Given this list of marker genes TGFB3, HSD3B7, POU4F2, OR1E2, COMMD10, CNTFR, IKZF2, NBEA, KMT2A, SOX10, TBX4, TNXB, CREB5 (NCBI Gene Id 9586), HOXC4, FOXB1 (forkhead box B1), ATG2B, SLC6A12, GRHL3, FBXL20, JAML, IGFBP3, TNFRSF1A, GPX1, GNAO1, ELF5, CEP15, ARHGAP5, MARCHF1, SOX21, SNX2, TEAD1, CD84, ZNF644, PTGER1, GHR, LASP1, NOTUM, COL8A1, EGFLAM, MBOAT7, FOXP2, RBMXL2, SREK1, VAMP8, BRINP3, GTF2E1, WDR47, LIMS1, SSBP3, SLITRK1, RBM14, TLL1, IL2, COL16A1, SPINK5, CNOT1, NTM-AS1, TFDP2 (transcription factor Dp-2), MARCKS, NMD3, ZBTB5, CPEB4 (NCBI Gene Id 80315), GADD45G, ZHX2, GATA4, SHOX2, WBP2NL, PAK5, TRIM47, HOXB4, HSPG2, ARL5B, CCDC6, SOX5, AGTR2, PRSS45P, FGFBP2 (NCBI Gene Id 83888, fibroblast growth factor binding protein 2), CD274, COL3A1, PIK3CD, NR2F2, IRF1, JDP2, ZFHX3, NRK, ACVR1, IP6K2, ZNF654, TCTA, SLITRK2, CCN4, SRSF1, ANKRD28, ENOX1, ORMDL3, PLOD2, RASL12, TNFAIP1, TIGD2, NECTIN1, HOXA2, SAFB, ZBTB18, FRS3, ARAF, TEC, GSK3B, FOXP3, PCDH12, FEZF2 (NCBI Gene Id 94016), FLT4, UBR5, SGO1, JARID2, PCDHA13, CCDC140, TMEM54, TGFB1, PHOX2B, MAGED1, ZFAND3, CDC42SE1, DTX3, INPP5F, CAPG, ZNF143, MLLT11, ETV5, CABP2, TFAP2D, EXD2, MRGPRF, COL25A1, SULF1, PARP8, EDN1, DLL4, PLAC1, CNIH2, ANKRD17, TRPM3, SLC26A7, ZNF362, ZMYND8, ARF6, CFL2, APOLD1, RAB6A, SNCAIP, FOXP1, PIP4P2, MTIF2, LGALS1, CAPN6 (NCBI Gene Id 827), DIPK2B, PREX2, HOXB3, ID2, PDGFB, GRK2, P2RY1, TIAL1, FAM43B, ADAMTS17, ANP32E, RBMS3, EMP1 (epithelial membrane protein 1), NFATC4, NTN5, MAP4K4, KIF3C, PER2, NAPG, MAST2, CTNND1, NKRF, TMEM38A, SPAG17 (NCBI Gene Id 200162), USP2, PCBP2, RNF128, CRY1, KLHL3, UQCRFS1, PRRG4, MTF2, SPARCL1, ESRRB, TACC2, FAP, TSEN34, XK, DDR2, PCDH10, BMP5, PHF6, EPHA2, NDRG2, SOX3, UXS1, BNC2, PAK1IP1, RNF182, BAHD1, LINC01138, ZNF516-DT, ERG, CLVS1, TAB3, CXCR5, TEK, S100PBP (NCBI Gene Id 64766), MITF, ELK3, IFNB1, RASL11A, SH3RF1, CDK11B, ZIC4, PAX3, CGRRF1, RHOA, ARHGAP6, IFT20, TRPS1, MSL3, FJX1, POU3F3, TMEM88 (transmembrane protein 88), CDK11A, INPP5E, CPNE1, MRPL45, NR3C2, PDE4D, PTOV1, IL4, LIF, KLHL24, PRICKLE4, HAPLN1, ZBTB32, ZIC1, PITX2, EXOSC9, SP3, LRATD2, CPO, KLF13, IRF4, here is a description of the gene set: Genes having at least one occurrence of the motif NANWGGAAAANN in the regions spanning 4 kb centered on their transcription starting sites. This matches the NFAT, NFATC transcription factor binding site V$NFAT_Q6 (v7.4 TRANSFAC). Human Gene Set: NFAT_Q6 studied in species Homo sapiens